The following is a description of a gene set: Any process that modulates the rate, frequency, or extent of a change in state or activity of a cell (in terms of movement, secretion, enzyme production, gene expression, etc.) as a result of a growth factor stimulus. Mouse Gene Set: GOBP_REGULATION_OF_CELLULAR_RESPONSE_TO_GROWTH_FACTOR_STIMULUS species: Mus musculus, and this is the list of marker genes: Sfrp4, Axin1, Ovol2, Fbn1, Ppp2r5b, Mt3, Ldlrad4, Atp2b4, Hif1a, Ppara, Zeb1, Dok5, Stk11, Sirt1, Vegfd, Trim33, Fbn2, Onecut2, Rbpj (NCBI Gene Id 791349), Htra3, Bcl9l, Cd109, Hdac1, Chrdl2, Fgf16, Gdf5, Fkbp8, Zfp703, Zdhhc17, Acvrl1, Notch1, Fstl4, Flcn, Zfp423, Wfikkn1, Ctdspl2, Agtr2, Tet1, Peg10, Sh3glb1, Sema6a, Ing2, Adamts3, Grem1, Twsg1, Sfrp1, Lrp2, Kdr (NCBI Gene Id 269657), Tmem204 (NCBI Gene Id 407831), Il12b (interleukin 12b), Skor2, Dand5, Ctnnb1, Snx1, Pbld1, Hspa5, Pparg, Nbl1, Smad7, Il4, Adgra2, Gpc3, Tgfb3, Hjv, Slc2a10, Pelo, Chst11, Adam17, Snx6 (sorting nexin 6), Wnt4, Hgs, Spry1, Sulf1, Mmrn1, Il17rd (NCBI Gene Id 69933), Eng, Ptprf, Nrep, Pals1, Prkcb, Abl1, Spred2, Msx2, Hif1an, Fstl1, Fstl5, Hsp90ab1, Sdcbp, Vegfc, Cadm4, Nanog, Brms1, Fam20c, Tgfb1i1, Furin, Ccn1, Skil, Snw1, Rgma, Smoc2, Gata4, Myof, Mtmr4, Cav2, Hipk2, Smad4, Tmprss6, Itga5, Apln, Lrrc32, Fst, Cav3, Sap130, Pdgfb, Ppp2r5d, Fgf2, Rasl11b, Arid4b, Ofd1, Dmd, Fbxl15, Itga3, Pdpk1, Smad3, Men1, Spart, Elapor2, Fgf1, Nptn, Spred1, Prdm14, Dstyk, Vwc2, Pbld2, Cask, Nog, Itgb3, Glg1, Dnm2, Sfrp2, Zbtb7a, Cilp, Wasf1, Ryr1, Sorl1, Foxd1, Crb2, Pmepa1, Got1, Ppm1a, Prdm16, Rbpms2, Cdkn1c, Cyfip1, Ilk, Slit2, Erfe, Tgfbr3, Tob1, Arid4a, Nedd4, Tfap2b, Mir675, Hdac2, Notch2, Prmt1, Htra1, Numa1, Rnf111, Adgrg1, Itgb1, Fgf18, Il17f, Wnt5a, Slc9a6, Cav1, Ep300, Ngly1, Fam89b, Onecut1, Eid2, Ski, Spred3, Tek, Pik3cb, Grb10, Cdh3, Lrp1, Dlx1, Hes1 (NCBI Gene Id 15205), Stub1, Vsir, Nrp1, Gata6, Pin1, Ptp4a3, Sostdc1, Tmem53, Gipc1, Smad6, Skor1, Tbx20, Cyfip2, Fzd4, Crim1, Lemd3, Tcf4, Ogt, Fzd1, Gpc1, Gpr155, Lrg1, Lemd2, Tsc22d1, Tnfaip6, Ulk1, Rbbp4, Fkbp1a, Agt, Npnt, Ccbe1, Crebbp, Ing1, Fgf4, Smurf2, Sap30l, Cited2, Tspan32, Lats1, Fstl3, Adamtsl2, Spry2, Lats2, Wnt1, Ptpn1, Cdkn2b, Robo1, Fgfbp1, Shisa2, Hhex, Ube2o (NCBI Gene Id 217342), Angpt1, Thbs1, Nrros, Hhip, Snx25, Veph1, Hrg, Xdh, Zfyve9, Creb3l1, Cidea, Cxcl13 (C-X-C motif chemokine ligand 13), Pdcd6, Neo1, Gdf3, Sulf2 (NCBI Gene Id 99203), Fgf9, Bmp4, Fuz, Smad2, Vasn, Cflar, Wfikkn2, Il12a, Cd63, Adamts12, Sap30, Grem2, Cer1, Usp15, Epn2, Zeb2, Fgfrl1, Ngf, Hes5, Ark2c, Fgf10, Jcad, Dab2ip, Nkx2-1, Tcf7l2, Bmp2 (bone morphogenetic protein 2), Cd59a, Xbp1, Ltbp1, Lox, Msx1, Vegfb, Kcp, Adissp, Fgfbp3, Sox11, Dll1, Emilin1, Sin3a, Lrit3, Fermt1, Gata3, Folr1, Vtn, Itga8, Nepn, Zfp451, Ngfr, Sost, Tgfbr3l, Cripto, Aspn, Spry4, Vwc2l, Cdh5, Vegfa, Gdf15, Prkd2, Trp53, Suds3, Tmem108, Gdf2, Hoxa13, Mmrn2, Smurf1, Rbbp7, Nrxn1, Myocd, Pin1rt1, Dcn, Scube3, Runx2, Bmper, Brms1l, Chrdl1, Dkk1, Chrd, Cnmd, Strap, Bambi, Sinhcaf, Ints9